Given this list of marker genes Vip, Oxtr, Kcnb1, P2rx1, Chrna6, P2ry1, Itgb3, Prkn, Sncg, Syt11, Fcer1g, Htr2a, Syk, Park7, Tgm2, Slc18a3, Pcp4, Crhr1, Pick1, Gdnf, Slc18b1, Gnat1, Slc18a1, Xlr4a, Adora2a, Cxcl12, Slc18a2, Mapk15, Htr7, Fcer1a, Drd2, P2ry12, Tor1a, Cadps, Actb, Agtr2, Cnr1, Chga, Cd300a, Slc22a3, Syt1, Fev, Crh, Mecp2, Prkcb, Stx1a, Myo5a, Comt, Rab3b, Xlr4b (NCBI Gene Id 27083), Htr1a, Syt7, Ghsr, Gabbr1 (NCBI Gene Id 54393), Gpm6b, Agt, Oxt, Maob, Slc22a2, Gck, Lgals3 (lectin, galactose binding, soluble 3), Slc22a1, Drd1, Nisch, Rab3a, Chrna7, Kpna4, Smpd3, Xbp1, Ffar3 (NCBI Gene Id 233080), Chrnb2, Adora2b, Ly6e, Crhr2, Sdhd, Hrh3, Slc29a3, Snca, Pink1, Slc6a4, Npy2r, Plcd1, Htr6, Dtnbp1, Nat8l, Ptger3, Abat, Chrna4 (cholinergic receptor, nicotinic, alpha polypeptide 4), Adora3, Fcgr3, Slc6a3, Rtn4, Chrm5, Drd3, Cartpt, Oprk1, Slc6a2, Kcna2, Grk2, Syt4, Grm2, Ptgs1, Slc29a4, Nos1 (NCBI Gene Id 76730), Htr1b, Entpd1, here is a description of the gene set: The directed movement of monoamines, organic compounds that contain one amino group that is connected to an aromatic ring by an ethylene group (-CH2-CH2-), into, out of or within a cell, or between cells, by means of some agent such as a transporter or pore. studied in species Mus musculus Mouse Gene Set: GOBP_MONOAMINE_TRANSPORT